The following is a description of a gene set: Shigella IpaB/C/D to ITGA/B-TALIN/VINCULIN signaling pathway. Pathway ID: N01081. Pathway type: Pathogen. Pathway class: nt06135 Cytoskeletal regulation (viruses and bacteria). Pathway Definition from KEGG: (IpaB+IpaC,IpaD) -> (ITGA5+ITGB1) -> (PTK2+PXN) -> (TLN+VCN) -> (ACTB,ACTG1) species: Homo sapiens Human Gene Set: KEGG_MEDICUS_PATHOGEN_SHIGELLA_IPAB_C_D_TO_ITGA_B_TALIN_VINCULIN_SIGNALING_PATHWAY, and this is the list of marker genes: TLN2, ACTB, PXN, ITGB1, VCL, TLN1, PTK2, ACTG1, ITGA5